Given this list of marker genes Apoc2, Hpdl, Bco2, Btd, Slc22a13, Slc25a51, Mocs1, Apom (NCBI Gene Id 80543), Ldlrap1, Pcca, Gsto1, Folr2, Slc19a2, Slc23a1, Pdxk, Slc25a16, Akr1b10, Aldh1l1, Nadk2, Pdzd11, Idh1, Fasn, Tcn2, Gchfr, Lrp8, Pdss2, Slc46a1, Gphn, Nadk, Rdh11, Cd320 (CD320 antigen), Sdc2, Akr1c20, Pank2 (NCBI Gene Id 99040), Mmaa, Slc23a2, Enpp1, Nadsyn1, Mtrr, Rbp4, Dcakd, Mmadhc, Lmbrd1, Nampt, Nudt12, Mocos, Akt1, Agrn, Mmut, Rnls, Ppcs, Coq2, Slc2a3, Lrp12, Sdc3, Nmnat3, Coq8b, Abcd4, Vkorc1, Pank3, Acacb, Pdss1, Vkorc1l1, Slc25a42, Akr1c6, Aox1, Abcc1, Calm2, Fpgs, Coq8a, Slc52a2, Mthfd2, Apoa1, Gpc4 (NCBI Gene Id 78622), Mccc2, Acaca, Rbp2, Slc52a3, Nt5e, Pnpo, Acp5, Spr, Calm1, Tpk1, Mocs3, Pank4, Gch1, Apoe, Coq5, Lrp1, Cblif, Bco1, Apoa2, Stard7, Coasy, Mthfr, Cyb5r3, Dhfr, Apoc2l, Mthfd1l, Mthfd2l, Coq7, Slc2a1, Naxe, Gpc3, Apoa4, Nmrk2, Lrp10, Nmnat1, Mtr, Mthfs, Mmab, Lrp2, Clps, Gpihbp1, Gsto2, Aco1, Bst1, Pcx, Naxd, Ubiad1, Ppcdc, Shmt1, Rfk, Sdc4, Hsp90aa1, Slc25a32, Sdc1, Slc5a6, Rbp1, Lpl, Plb1, Aldh1l2, Mthfsl, Nfs1 (NCBI Gene Id 98843), Ttr (transthyretin), Slc19a1, Coq4, Slc5a8 (NCBI Gene Id 216225), Pccb, Coq3, Nmrk1, Slc25a19, Calm3, Naprt, Pnlip, Pank1, Mmachc, Coq9, Nmnat2, Vnn1, Gpc2, Gpc6, Flad1, Pts, Aasdhppt, Coq6, Slc19a3, Apob, Gpc5, Mthfd1, Cyb5a, Thtpa, Gpc1, Shmt2, Lrat (NCBI Gene Id 99631), Akr1c21, Ttpa, Mccc1, Hlcs, Nnmt, Nos3, Cd38 (NCBI Gene Id 12494), Qprt, here is a description of the gene set: studied in species Mus musculus Metabolism of vitamins and cofactors Mouse Gene Set: REACTOME_METABOLISM_OF_VITAMINS_AND_COFACTORS